The following is a description of a gene set: Human Gene Set: GNF2_EIF3S6 species: Homo sapiens Neighborhood of EIF3S6 eukaryotic translation initiation factor 3, subunit 6 48kDa in the GNF2 expression compendium Neighborhood of EIF3S6, and this is the list of marker genes: RPS21 (NCBI Gene Id 6227), RPL12, RPL18A, RPS12, RPL15 (NCBI Gene Id 6138), RPL13A, RPS16, RPS20, RPL27A, INTS8, ATP5MG, EIF3E, DAP3, RPL34, RPL3, RPL6, EIF3K, RPL35, RPL30, RPS18, RPS7, RPS13, RPL36A, RPSA, MTIF2, RPL36AL, EIF3F, CCDC59, SLC7A5P1 (solute carrier family 7 member 5 pseudogene 1), UBA52, RPL21, GDI2, NACA, EIF3H, RPL4, PABPC3, UQCRB, RPL7A, RPS28, RPL41, RPL29, RPL37, EEF1B2, EIF4B (NCBI Gene Id 55378), RPL13, PTMA, RPL14, RPL22, RPL38, RACK1, RPL17, RPL35A, RPS10, RPL5, NSA2, HMGN1, CNOT7, RPS19, RPL24, POLR1D, RPL27, RPS6, EIF3D, RPL23, RPL31, RBBP6, RPL28, CDV3, RPL10A, RPL36, FAU, COX7C (NCBI Gene Id 1350), RPL11 (NCBI Gene Id 6135), HNRNPA1, BTF3, RPL39, RPS29, PABPC1, SRSF7, PNRC2 (NCBI Gene Id 55629), NPM1, RPL8, PAPOLA, RPS15, RPL18, SLC25A6, RPS14, ATP5MC2, RPL7, NOL11, RPS2, KARS1, RPLP2, DDX50, TAF1D, RPL19, RPS8 (NCBI Gene Id 6202), RPS25, RPS3A, EIF3L, RPL32, RPL23A, SRRM1, RPS4X, UXT, AIMP1, EEF1G, RPS23, GTF3A, RPL9, NAP1L1, LSM7, RPS3, DDX47, RPS17, EPRS1, PMPCB, RPS24, FBL, ST13, RPS9